The following is a description of a gene set: electronically inferred by orthology from the curated human pathway part of: DNA Repair Reactome Pathway: Nucleotide Excision Repair This event has been computationally inferred from an event that has been demonstrated in another species.<p>The inference is based on the homology mapping from PANTHER. Briefly, reactions for which all involved PhysicalEntities (in input, output and catalyst) have a mapped orthologue/paralogue (for complexes at least 75% of components must have a mapping) are inferred to the other species. studied in species Mus musculus, and this is the list of marker genes: Rps27a, Gtf2h4, Ube2n, Rfc1, Pold1, Xpc, Polr2f, Xpa, Ddb1, Ercc6, Polk, Prpf19, Pcna, Ubb, Ino80b, Pole, Ccnh, Polr2a, Cul4a, Pold2, Polr2b, Gtf2h2, Polr2c, Tcea1, Ercc4, Usp45, Rnf111, Ercc1, Chd1l, Polr2k, Xrcc1, Ino80c, Ercc2, Tfpt, Polr2e, Nfrkb, Lig1, Zfp830, Cul4b, Ercc3, Uvssa, Polr2l, Cops6, Polr2i, Pole2, Rfc3, Xab2, Rpa1, Yy1, Pold4, Sumo1